Given this list of marker genes Fgf10, Adipor1, Ltb4r2, Glipr2, Itga3, Irs2 (insulin receptor substrate 2), Scrib (NCBI Gene Id 54559), Mtor, Zeb2, Cd63, Dock1, Capn7, Insl3, Dusp10, Macir, Krt16 (keratin 16), Pten, Eppk1, Coro1c, Epb41l5, Sema3a, Map4k4, Hif1a, Apela, Nanos1, Kank2, Pfn2, Jun, Hyal1, Pfn1, Src, Pkn2, Ctsh, Sash1, Plcg2, Apc, Tesk1, Ptk2 (NCBI Gene Id 14083), Dock5, Acta2, Prkce, Tgfbr2, Evl, Fgf8, Itga2, Kank1, Lrg1, Bmpr2, Fgf7, Ccr6, Ptprr, Mcc, Kitl, Tacstd2, Tgfb2, Actn4, Krt2 (NCBI Gene Id 208726), Mmp9, Enpp2, Sox9, Wdpcp (NCBI Gene Id 216560), Marveld3, Vim, Tacr1, Prox1, Foxf1, Actg2, Mapre2, Clasp1, Arhgap5, Rreb1, Snai2, Rtn4, Hbegf, Gab2, Ppard, Tmigd1, Aqp1, Iqsec1, Gdf6, Tac1, Hdac6, Pkn1, Ptpn11, Irs1, Rock1, Wnt5a, Arf6, Rab11a, Fat2, Snai1, Pkn3, Grhl2, Ptprg, Adam9, Acta1, Actc1, Ppm1f, Daam2, Anln, Kit, Vil1, Dab2ip, Arsb (NCBI Gene Id 71784), Has2, Epb41l4b, Ptpn23, Coro1a, Tgfbr3, T, Fermt1, Macf1, Serpine1, Clasp2, Il4, Smad4, Ifng, Rab25, Plcg1, here is a description of the gene set: Mouse Gene Set: GOBP_TISSUE_MIGRATION species: Mus musculus The process in which the population of cells that make up a tissue undergo directed movement.